The following is a description of a gene set: studied in species Homo sapiens Human Gene Set: REACTOME_DISPLACEMENT_OF_DNA_GLYCOSYLASE_BY_APEX1 Displacement of DNA glycosylase by APEX1, and this is the list of marker genes: NTHL1, MUTYH (NCBI Gene Id 4595), OGG1, MPG, TDG, UNG, SMUG1, MBD4, APEX1